Given this list of marker genes EGLN3, CYP1B1, IGF1R, KYNU, TFPI2, NEBL, PEG10, ZBTB20, VWDE, CKLF, THSD7A, CEMIP2, CCDC171, GJA1, ANO3, ADGRL2, EPHA3, MGST1, TWIST1, IRX3, ITM2A, CDH2, UACA, COL11A1, HAPLN1, SMARCA2, here is a description of the gene set: The molecular pathways activated in response to acute cisplatin exposure, as well as the mechanisms involved in the long-term development of cisplatin-resistant cancer cells remain unclear. Using whole genome oligonucleotide microarrays, we have examined the kinetics of gene expression changes in a cisplatin-sensitive cell line, A2780, and its cisplatin-resistant derivative, ACRP. Both sensitive and resistant cell lines exhibited a very similar response of p53-inducible genes as early as 16 h after treatment. This p53 response was further increased at the 24-h time point. These experiments identify p53 as the main pathway producing a large-scale transcriptional response after cisplatin treatment in these cells containing wild-type p53. Consistent with a role for the p53 response in cisplatin sensitivity, knockdown of the p53 protein with small interfering RNA led to a twofold decrease in cell survival in the resistant cells. In addition, our analysis also allowed the identification of several genes that are differentially expressed between sensitive and resistant cells. These genes include GJA1 (encoding connexin 43 (Cx43)) and TWIST1, which are highly upregulated in cisplatin-resistant cells. The importance of Cx43 in drug resistance was demonstrated through functional analyses, although paradoxically, inhibition of Cx43 function in high expressing cells led to an increase in drug resistance. The pathways important in cisplatin response, as well as the genes found differentially expressed between cisplatin-resistant and -sensitive cells, may represent targets for therapy aimed at reversing drug resistance. Genes consistently up-regulated in ACRP cells (ovarian cancer, resistant to cisplatin) compared to the parental sensitive A2780 cells, regardless of cisplatin exposure. Human Gene Set: LI_CISPLATIN_RESISTANCE_UP species: Homo sapiens from publication Li J, Wood WH 3rd, Becker KG, Weeraratna AT, Morin PJ (PMID 17072341)